Given this list of marker genes Fktn, Rheb, Cnot9, Ago1, Xylt2, Alyreffm16, Nucb2, Rock2, Pth, Pcna, Slc41a1, Ube2d2b, Ankfy1, Rprd2, Sox13 (NCBI Gene Id 98702), Dhx40, Galnt17, Slc16a2, Tecr, Krtap5-5, Gdf5, Zup1, Alyreffm15, Tspan11, Arl8b, Fbxl17, Brpf3, Cfl2, Plekhh1, Tcf12, Idua, Enc1, Arl4a, Magi2, Heyl, Slc4a5, Six3, Ralgapb, Ocln, Tox3, Gsk3b, Zfp142, Pcdh10, Dcaf8l, Zfp938 (NCBI Gene Id 237411), Wnt7a (NCBI Gene Id 22421), Grem2, Dars1, Dcaf17, Adam2, Phactr2, Anxa2, Cntd1, Syn1, Hook3, Clstn1, Ppp6r1, Ccdc174, Bcat1, Plxna4, Ctla4, 4921536K21Rik, Ikbkg, Glod5, Coro1c, Dgkk (diacylglycerol kinase kappa), Gpr156 (G protein-coupled receptor 156), Mat2a (methionine adenosyltransferase 2A), Syndig1l (synapse differentiation inducing 1 like), Dnase1l3, Coro2b, Arhgef9, Rit2, Agap1, Rere, Trem3, Adgrb1, Mier1, Tnrc6b, Phlpp2, Zfp157, Fgf14, Rbfox2, St6galnac3 (NCBI Gene Id 20447), Atp1a3, Fam124a (family with sequence similarity 124, member A), Tmco5b, Dynll2, Klk5 (kallikrein related-peptidase 5), Apba1, Flot2, Rapgef3, Tead1, Svs3b, Rhot1, Igf1r, Kcne1, Csmd2, Gpr21, Sez6l2, Zscan20, Sgms1, Rad54l2, Alyreffm10, Zxdb, Zfp385a, Ephb2, Slc24a2, Creb3l2, Dusp15, Smg7, Hipk1, Map4k4, Carmil1 (NCBI Gene Id 68732), Eps8l1 (NCBI Gene Id 70195), Car10, Synm, Rnf20, Rab3d, Pip5k1c, Igf1, Cdc42, Tmed5 (transmembrane p24 trafficking protein 5), Slc4a8, Cgn, Thra, Ntrk2, Kif1b, Otof, Tpst2, Hsf5, Alyreffm14, Grhl2, Cbfa2t3, Cdyl2, Pak2, Cldn23, Alyreffm11, Cpeb3, Ssu72, Crtac1, Adam12, Alyreffm13, Notch2, Rora, Hic2, Elp4, Plekhg4, Zmym3, Alyreffm17, Celf2, Ark2c (NCBI Gene Id 72870), Dlg2 (discs large MAGUK scaffold protein 2), Tspan18, here is a description of the gene set: Genes predicted to be targets of miRBase v22 microRNA mmu_miR_882 in miRDB v6.0 with MirTarget v4 prediction scores > 80 (high confidence targets). Mouse Gene Set: MIR_882 from publication Chen Y, Wang X (PMID 31504780) studied in species Mus musculus